Given this list of marker genes NFKB1, IKBKB, IFNA1, IFNA7, IFNA13, IKBKG, IFNA14, RELA, IFNA8, IFNA16, IFNA21, RIGI, IFNB1, IFNA10, IFNA17, MAVS, IFNA6, NFKBIA, IFNA2, CHUK, IFNA4, IFNA5, here is a description of the gene set: Pathway Definition from KEGG: RNA -> RIGI -> MAVS -> IKK -> NFKBIA -> NFKB => (IFNA,IFNB1) species: Homo sapiens Human Gene Set: KEGG_MEDICUS_REFERENCE_RIG_I_NFKB_SIGNALING_PATHWAY RIG-I-NFKB signaling pathway. Pathway ID: N00688. Pathway type: Reference. Pathway class: nt06519 RLR signaling.